Given this list of marker genes SRSF5, FKBP5, PRKG1, USP10, MMP1, AHRR, C1S (complement C1s), HAS1, HSPD1 (NCBI Gene Id 56733), CYTH1, IQGAP1, ITGB6, CAMKK2, CRTC1, FUS, RHOB, OTUD4 (NCBI Gene Id 95936), ADGRF1, RNF144B (NCBI Gene Id 255488), MYH11, ATP6V0D2, ADAMTS1, TAOK1, IGLJ3, MATR3, BTG2, HSP90AB1, MAPKAPK2, ITLN1, NR4A3, EIF1, B3GNT5, IL6ST, MVD, FOLH1, MAT2A, EPAS1 (NCBI Gene Id 2034), MET, AZGP1, PGS1, SRPRA, SEC61A1, RNF125, GABPB2, APOL6, TTC3, STC1, NEAT1, MICALL2, DDX3X, ANK2, AQP4, FGG, SCAF11, TOP1, SERPINE1, CCL20, HOXC8, XAGE1A, SOD2, SERPINB2, CTNNA1, RAB12, WDR1, ACTR2, CYP1A1, UFM1, AGTR2, STEEP1, RCAN1, EZR, ZFP36L2, RASEF, NFASC, NAMPT, SUPT16H, ZNF649, MCL1, ENG, DUSP1, FER (NCBI Gene Id 2241), here is a description of the gene set: species: Homo sapiens Human Gene Set: FALVELLA_SMOKERS_WITH_LUNG_CANCER Evidence in animal models has suggested an association between susceptibility to lung tumorigenesis and gene-expression profiles in normal lung. Here, we compared RNA pools from normal lung tissue of lung adenocarcinoma patients (cases) or non-lung cancer patients (controls) by hybridization of whole-human genome expression arrays. Principal component analysis identified a gene-expression signature of genes that distinguishes cases from controls as well as smokers from nonsmokers. Elevated mRNA levels of one of these genes, AZGP1, were significantly associated with disease status. These results support the hypothesis that differences in the gene-expression levels of the normal tissue may be predictive of genetic predisposition to lung cancer in humans. Genes that distinguish normal from cancer (lung adenocarcinoma) samples and smokers from non-smoking subjects. from publication Falvella FS, Spinola M, Pignatiello C, Noci S, Conti B, Pastorino U, Carbone A, Dragani TA (PMID 17724461)